Given this list of marker genes SCYL2, NDN, SNRPN, KDM5A, TMEM147, STUB1, MAGEL2, SACS, OCA2, here is a description of the gene set: species: Homo sapiens Parietal cortical atrophy Human Gene Set: HP_PARIETAL_CORTICAL_ATROPHY Atrophy of the parietal cortex.